Given this list of marker genes RIMS1, ARL2BP, KIAA1549, PDE6B, NOTCH2NLC, CA4 (carbonic anhydrase 4), MKKS, VSX1, LTBP2, PTPN22 (NCBI Gene Id 5779), AIPL1, NPHP1, CYP1B1, IMPG1, PDE6A, FAM161A, IFT172, MERTK (MER proto-oncogene, tyrosine kinase, NCBI Gene Id 10461), USP45, LZTFL1, GUCA1B, AHSG, AHI1, CFAP410, DHDDS, CARS1, ADAM9, HARS1, ITGB6 (integrin subunit beta 6), KIZ, LYST, DKK1, GPR143, ERCC1, HLA-B (NCBI Gene Id 730410), SLC1A3, MAPT, AP1B1, ERCC3, STAT4, TLR4, FOXC1, IDH3A, TNF, SCLT1, DRAM2, GTF2H5, SEMA4A, IMPG2, GALC, MCOLN1, NOD2, LSS, PRPF3, PNPLA6, RTN4IP1, CABP4, IL10, FAS, IFT140, MFRP, RP9, TTLL5, ERCC4, CLTRN, PDE6G, RPE65, GJA1, IDH3B (NCBI Gene Id 3420), ANTXR1, BLOC1S5 (biogenesis of lysosomal organelles complex 1 subunit 5), CST6, BBS9, MC1R, ATF6, DCN, TOPORS, EYS, PRCD, ZNF408, AFG3L2, GTF2E2, LRMDA, BBS5, TRANK1, ELOVL1, POLH, IFT27, TARS1, AIRE, SPATA7, CEP290, WDR45, PCYT1A, PITPNM3, NRL, PAX6 (NCBI Gene Id 5080), GDF6, GNB3, ALMS1, ARL6, NEK2, HLA-A, RD3, BEST1, LRAT, PLCD1, NR2E3, CC2D2A, RIMS2, DDB2 (NCBI Gene Id 1643), IL23R, SLC6A19, PDE6C, USH2A, RP1, TTC8, EFEMP1, KRT14, ELOVL4, ARHGEF18, SLC7A14, RP1L1, OVOL2, BBS1, GJB2, AP3B1, OPN1LW, PROM1, RAB28, ZEB1, INPP5E, HPS1, BBS12, CDHR1, ALDH3A2, CACNA2D4, GJB6, NLRP1, SAG, OFD1, RGR, TGFBI, OCA2, POMGNT1, MPLKIP, WDPCP, HPS6, ITM2B, TYR, TUB, BBS4, FZD5, CACNA1F, FSCN2, IL12A, BBS2, BBS10, NSUN2, PSAP (prosaposin), SREBF1, IFT88, TULP1, CFAP418, ABCA4, HADHA, EPCAM, RPGRIP1, MYOC, TIMM8A, RLBP1, IMPDH1, RGS9BP, UNC119, ZNF513, KRT5, RDH12, UBAC2, CLRN1, GRHL2, IFNGR1, REEP6, CFI, MCAT, CNGA3, SLC39A4, TRIM32, RBP3, OPN1MW, HLA-DRB1, IQCB1, IL12A-AS1, SLC24A5, DHX38, DCT, CEP19, FOXC2, KLHL7, RPGR, EDNRA, COL8A2, AHR, RHO, ERAP1, PRPF4, CRB1, TEK, PCARE (photoreceptor cilium actin regulator), PRPF6, CRYGC, MKS1, IKZF1 (NCBI Gene Id 55429), PDE6H, PRPH2, CLCC1, TRIM44, TLCD3B (NCBI Gene Id 83723), COL4A1, CTNS, PERCC1, KLRC4, IFT74, KCNJ13, RP2, PRPF31, AGBL5, AP3D1, GAN, RDH5 (NCBI Gene Id 81991), TAT, PCNA, C4A, HK1, TUBB4B, RGS9, CCR1, COL17A1, ATXN7, GUCA1A, MEFV, ERCC6, GUSB, LCA5, OPN1SW, LIG4, NLRP3, ARL3, WNT10A (NCBI Gene Id 93651), CEP250 (centrosomal protein 250), RAX2, RNF113A, CHST6, CRX, SCAPER, ESR1, BBS7, KCNV2, ROM1, AARS1, XPC, SNRNP200, GNAT2, POC1B, ERCC8, PRPF8, BBIP1, MAK, KRT3, CNGB3, PIKFYVE, C1QTNF5, CERKL, ERCC5, GUCY2D, XPA, ERCC2, CNNM4, CNGB1, CEP78, MBTPS2, ST14, SLC45A2, POLA1, TACSTD2, KRT12, NMNAT1, CFH, SDCCAG8 (NCBI Gene Id 10806), CNGA1, TP63, SCN1A, HGSNAT (heparan-alpha-glucosaminide N-acetyltransferase), here is a description of the gene set: Photophobia Human Gene Set: HP_PHOTOPHOBIA Excessive sensitivity to light with the sensation of discomfort or pain in the eyes due to exposure to bright light. studied in species Homo sapiens